The following is a description of a gene set: Inflammation (due to infection or irritation) of the pharynx. Pharyngitis Human Gene Set: HP_PHARYNGITIS species: Homo sapiens, and this is the list of marker genes: NFKB2, TCIRG1, TNFRSF1A, PTPN22, ALG12, CLPB, P4HA2, HLA-B, ELANE, HLA-DRB1, SH2D1A, SLC29A3, GFI1, CXCR4, SRP19, XIAP, HLA-DPB1